The following is a description of a gene set: Lysosome-related organelles have versatile functions, including protein and lipid degradation, signal transduction and protein secretion. The molecular elucidation of rare congenital diseases affecting endosomal-lysosomal biogenesis has given insights into physiological functions of the innate and adaptive immune system. Here, we describe a previously unknown human primary immunodeficiency disorder and provide evidence that the endosomal adaptor protein p14, previously characterized as confining mitogen-activated protein kinase (MAPK) signaling to late endosomes, is crucial for the function of neutrophils, B cells, cytotoxic T cells and melanocytes. Combining genetic linkage studies and transcriptional profiling analysis, we identified a homozygous point mutation in the 3' untranslated region (UTR) of p14 (also known as MAPBPIP), resulting in decreased protein expression. In p14-deficient cells, the distribution of late endosomes was severely perturbed, suggesting a previously unknown role for p14 in endosomal biogenesis. These findings have implications for understanding endosomal membrane dynamics, compartmentalization of cell signal cascades, and their role in immunity. Genes up-regulated in B lymphocytes from patients with primary immunodefiency syndrom. species: Homo sapiens from publication Bohn G, Allroth A, Brandes G, Thiel J, Glocker E, Schäffer AA, Rathinam C, Taub N, Teis D, Zeidler C, Dewey RA, Geffers R, Buer J, Huber LA, Welte K, Grimbacher B, Klein C (PMID 17195838) Human Gene Set: BOHN_PRIMARY_IMMUNODEFICIENCY_SYNDROM_UP, and this is the list of marker genes: SEPTIN10, CALU, TIAM1, TXN, ATF5, TOP2A, TAGLN2, EXPH5, SSR2, SMC2, SELPLG, SRSF3, CD86, CANX, KLK1, RPL14, NLRP1, MKI67 (NCBI Gene Id 4288), ASPM, TMOD1 (NCBI Gene Id 7111), RORA, HOMER3, OAT, RPSA, GLDC, ATF4 (NCBI Gene Id 468), RPS5, UBE2C, DENND2D, BLM, MORF4L2, HAX1 (NCBI Gene Id 10456), P2RX5, DLGAP5 (DLG associated protein 5), MLEC, NT5DC2, CENPE, NMD3, SHMT2, APOBEC3G, HILPDA, IL32, DLG1, FERMT2 (NCBI Gene Id 10979), CDKN1B, NUSAP1